The following is a description of a gene set: Human Gene Set: ACTTTAT_MIR1425P species: Homo sapiens Genes having at least one occurence of the motif ACTTTAT in their 3' untranslated region. The motif represents putative target (that is, seed match) of human mature miRNA hsa-miR-142-5p (v7.1 miRBase)., and this is the list of marker genes: PPM1G, RPS6KA5, SSH2, DDHD1, NTRK3, GRSF1, CNEP1R1, STAG1, RSF1, TMEM54, UBR1, MARCHF6, ACTN4, TPBG, MSH6, SETD1A, PURA, SPSB1, PAIP1, ETV1, CD69, RPS6KA4, SACS, CCNT2, AP1G1, DSTYK, SORBS1, FBXO30, HOXA13, AHR, WWP1, RALGAPA1, FZD7, MCL1, LRP2, HSPA8, NUDT22, SHANK2, RNH1, VMP1, TGFBR2, SREBF1, OSR1, TP53INP1, MFSD14A, ADAMTS1, DCUN1D4 (defective in cullin neddylation 1 domain containing 4), GPATCH8 (G-patch domain containing 8), PAPOLB, FXYD3 (NCBI Gene Id 5349), NFAT5, UBE4A, CRK, HOXB4, TANC1, GAS7, WDR26, FBXL3, ARID4B, SYT7, CPEB2, TUT4, ULK1, MBIP, ZFPM2, SP2, FAM131B, KLHL14, MBD2, DCHS1, NPAS4, MASTL, CMIP, DNAJC25, TAOK2, MTLN, NFE2L2, PBX3, ZFP36, HNRNPH3, BNIP2, C2CD2, SON, TRIP10, CCNG2, LUZP2, EIF4E3, UBE3C, ARID2, MED28, PRP4K, NIBAN2, NRP1, MEA1, SLC25A27 (NCBI Gene Id 9481), RAB6B, EMC4, FNDC3B, CLCN3, RGMA, ACIN1, EYA4, SLC4A4, NPAT, H3-3A, JPT1, CAMK2A, CDC37L1, RHOT1, COL4A3, BTBD7, CDK17 (cyclin dependent kinase 17), ALS2, FIGN, SPOCK2, FCHO2, FOS, FGF13, C14orf28, RBBP8, PAPPA (NCBI Gene Id 5069), APBB3, SRF, ROBO1, BRPF3, STK35, LHX8, EP300, DNAJC7, ZNF503, KLF11, TRIM3, MED12L, RC3H1, IL18BP, AFF4, CUL2, DUSP2, CEP97, ZBTB47, SLC22A23, RETREG1, ADAMTS5, TRIM36, MAT2B, VANGL1, BTBD1, SPEN (NCBI Gene Id 348488), CAPN7, IGF2BP3, STC1 (NCBI Gene Id 82914), LRP1B, CNOT11 (NCBI Gene Id 55571), IGF1, SGMS1, KCNRG (NCBI Gene Id 283518), SUN1, NRG1, FAM107B, TSC22D2, BHLHE41, SLC36A1, CIC, MIER3, KITLG, RIC8B, KCNJ3, GCH1, CUL4A, SOX5, SIX4, MYCN (MYCN proto-oncogene, bHLH transcription factor, NCBI Gene Id 53360), SDCBP, NETO2, RHOQ, ARHGEF40, KIT, JMJD1C, MGAT4B, MIR137HG, PTPN4, ADGRL3, ENSG00000204117, GOPC, UBE2A, USP46, SYNJ1, LMX1A, CPSF6, TAFA1, EXOC5, EPAS1, BTG3, MKLN1, HDLBP, UCHL3, RPS25, PCBP2, ADGRB3, ATXN7L2, RAB11FIP5, RETREG2, GRM7, CBLN4, PLEKHA3, RERG, ZCCHC14, CAMTA1, SETD2, BTBD10, ATP1B1, HIPK1, BVES, SNX16, CHSY3, SCOC, BTG1, ATP2B1, ARK2C, CPEB3 (cytoplasmic polyadenylation element binding protein 3), ZFX, RHOC, CDK5, CPEB4, FOXJ2, SLC18A2, PLXNA2, MED14, RCN2, TLE4, TCF12, OTUD4, ZNF512B, MYO1D, TRPC4AP, CNNM4, UBE2D1, DIO2, ABCG4, MGLL, TBC1D9, ACKR3, ZDHHC17, ELAVL4, MYF5, PDS5B, HERPUD1, SPCS2, CHD9, PCBP1, ATG16L1, QKI, SLC17A7, C8orf34, EGR3, GPR88, ELAVL2, CBX3, ARGLU1, KLF10, RHOA, ALCAM, FAM91A1, OTX2, SLAIN1, ABCA1, BAZ2A, UQCRFS1, CELSR1, TAF10, MBD5, REV3L, RNF128, ST8SIA2, HLTF, BECN1, EFCAB14, SRI, PCGF3, FNDC3A, LRP12, VPS54, ZFYVE21, EGLN3, HMGCLL1, MMP24, BMP2, RTN1, ZFAND3